The following is a description of a gene set: Mouse Gene Set: GOBP_POSITIVE_REGULATION_OF_SYNAPTIC_PLASTICITY studied in species Mus musculus A process that increases synaptic plasticity, the ability of synapses to change as circumstances require. They may alter function, such as increasing or decreasing their sensitivity, or they may increase or decrease in actual numbers., and this is the list of marker genes: Anapc2, Mecp2, Unc13a, Cdc20, Adcy8, Ephb2, Neurod2, Ssh1, Map1b (microtubule-associated protein 1B), Ptgs2, Cfl1, Cplx2, Dbn1, Mmp9